The following is a description of a gene set: from publication Browne EP, Wing B, Coleman D, Shenk T (PMID 11711622) The effect of human cytomegalovirus (HCMV) infection on cellular mRNA accumulation was analyzed by gene chip technology. During a 48-h time course after infection of human diploid fibroblasts, 1,425 cellular mRNAs were found to be up-regulated or down-regulated by threefold or greater in at least two consecutive time points. Several classes of genes were prominently affected, including interferon response genes, cell cycle regulators, apoptosis regulators, inflammatory pathway genes, and immune regulators. The number of mRNAs that were up-regulated or down-regulated were roughly equal over the complete time course. However, for the first 8 h after infection, the number of up-regulated mRNAs was significantly less than the number of down-regulated mRNAs. By analyzing the mRNA expression profile of cells infected in the presence of cycloheximide, it was found that a minimum of 25 mRNAs were modulated by HCMV in the absence of protein synthesis. These included mRNAs encoded by a small number of interferon-responsive genes, as well as beta interferon itself. Cellular mRNA levels in cytomegalovirus-infected cells were compared to the levels in cells infected with UV-inactivated virus. The inactivated virus caused the up-regulation of a much greater number of mRNAs, many of which encoded proteins with antiviral roles, such as interferon-responsive genes and proinflammatory cytokines. These data argue that one or more newly synthesized viral gene products block the induction of antiviral pathways that are triggered by HCMV binding and entry. Genes down-regulated in primary fibroblast cell culture point after infection with HCMV (AD169 strain) at 8 h time point that were not down-regulated at the previous time point, 6 h. Human Gene Set: BROWNE_HCMV_INFECTION_8HR_DN studied in species Homo sapiens, and this is the list of marker genes: MAGEA10 (NCBI Gene Id 4109), FEM1B, AHDC1, LPXN, MRPS31, MYC, PLEKHO2, H4C12, TMEM30B, POLR1F, CEBPD, ZNF623, TWIST1, ZNF7, ANKMY2, SACS, PLIN2, GINS1, FZD2, DST, LRP8, ATAD2B, LINC00847, NAV3, SPN, VDR, ITGA3 (NCBI Gene Id 4454), RIPOR2, TRIB2, ZIC1, PIM1, SMAD3, CMAHP, CDC42EP3, PLAU, MIR3648-1, TPX2, VWA5A, MSC, PTGER1, KIF2C, GZMK, BMP4, HOXA11, ERCC6, TFCP2, KRT34, XPC